The following is a description of a gene set: Human Gene Set: GSE14350_IL2RB_KO_VS_WT_TEFF_UP Genes up-regulated in comparison of effector T cells from IL2RB defficient mice versus effector T cells from wild type animals. from publication Yu A, Zhu L, Altman NH, Malek TR (PMID 19185518) species: Homo sapiens Interleukin-2 receptor (IL-2R) signaling is essential for T regulatory (Treg) cell development and homeostasis. Here we show that expression of IL-2Rbeta chains that lack tyrosine residues important for the association of the adaptor Shc and the transcription factor STAT5 in IL-2Rbeta-deficient mice resulted in production of a normal proportion of natural Treg cells that suppressed severe autoimmunity related with deficiency in IL-2 or IL-2R. These mutant IL-2Rbeta chains supported suboptimal and transient STAT5 activation that upregulate the transcription factor Foxp3 to normal amounts in natural, but not induced, Treg cells. Using cells T cell obtained from normal C57BL/6 mice and mice harboring Treg cells with impaired IL-2R signaling, gene expression profiling revealed many targets in peripheral natural Treg cells that were IL-2-dependent and a substantial overlap between the Treg cell IL-2-dependent gene program and the Treg cell transcriptional signature. Collectively, these findings demonstrate that a critical, and perhaps minor, subset of IL-2-dependent targets in Treg cells is indexed to a low IL-2R signaling threshold and that a substantial proportion of the Treg cell gene program is regulated by IL-2. CD4 T effector cells also showed many IL-2R-dependent gene and these also overlapped in a distintive manner with the IL-2-dependent genes of Treg cells and the Treg gene signature., and this is the list of marker genes: FAAP20, RIC8B, SH3BP4, CCDC28B, CLK1, MAST4, BACH2, NSUN4, BICD2, DIP2B, ZNF703, ARFIP1, SLC29A3, PTOV1, BTLA, RNF11, VPS39, NBDY, DCTN2, HLA-G, ZHX2, CCR7, GPR174, MYH10, JOSD2, TMED4, CTSS, PLAGL1, CDC37, FOXN3, RAB11FIP5, BPHL, TNNI1, CLEC1A, DPEP3, CUEDC1, NCOA7, CCDC122, DNAAF4, IFTAP, UBE2J1, ZCCHC18, SLC27A4, BICDL1, LANCL1, LRIG2 (leucine rich repeats and immunoglobulin like domains 2), IVD, SCN1A, NDUFA3, FYN, KIF13A, TSPAN3, CD74, GSTM4, PDK2, CRACD, MAPK8, RTL6, RILPL2, WDFY1, TMEM50B, ID3, P4HTM, STYX, BMPR2, ST8SIA6, C6orf132, TACC1, NCF4, RNF122, RORA, KCNMB4, NEK9, TNFSF8, IL1R2, SOWAHC, RFX5, NCKIPSD, DBNDD2, PSRC1, POLR2M, MAPRE3, IZUMO4, ADH4, HOXA7 (NCBI Gene Id 3204), TRPA1, SDHAF4, RERE, OTX1, CCR6, ERGIC1, TNFSF11, SCIN, SEMA4F, THRSP, LNPEP, TBC1D5, POU2AF1, SLC9B2 (solute carrier family 9 member B2), PCBD2, NKX6-1, RAB43, NFAT5, PHKA2, AFF3, TGIF1, MRTFB (myocardin related transcription factor B), ZNRF1, DCLK1, PER1, ANKRD50, CD96 (NCBI Gene Id 337949), GRAMD1B, HEXIM1, HLA-DRB1, CNPY3, UVSSA, MAST2, MCOLN2, HERPUD2, PRKCE, PARP8, HLA-DOA, IGFLR1, SQOR, CYBA, ABCD3, TMEM154, RNF216, CHMP1A, ZBTB7A, ATL3, STON1, DENND5A, ABCA3 (NCBI Gene Id 21), MARCKSL1, TMEM42, PLXNC1, IFIH1, TIAM1, MORN1, BLTP3B, TNFSF4 (TNF superfamily member 4), PTPRS, MYO1E, MAP4K3, BATF, NLRX1, COX14, RNF43, LRIG1, ZC3H12D, TM4SF5 (NCBI Gene Id 9032), DCLK2, HAO2, BLOC1S5, KDELR1, IGF1R, MYPOP, PARP3, ZNF445, SLC9A9, NMRK1, ATXN1, ATP9B, ADH1C, NOP53, TBC1D32, VPS13A, HVCN1, SIAH2, KCNK10, POLK, IER3IP1 (immediate early response 3 interacting protein 1), NFKB2, CD4, BTBD2, DVL1, ERGIC3, PHF20L1, CILK1, DGLUCY, RPL13A, DAPL1, RIC8A, PSME2, BCAS1, ARHGAP20 (NCBI Gene Id 57569), SSH2, BCL2L14, ACADVL, PRDX2 (peroxiredoxin 2), S100A8, ADIPOR2, ANKRD12, DIP2C, DYNLT3, NR4A2, DUSP19, ZMIZ2